The following is a description of a gene set: Genes up-regulated in liver from mice with liver specific knockout of POR. studied in species Mus musculus from publication Weng Y, DiRusso CC, Reilly AA, Black PN, Ding X (PMID 16006652) Mouse Gene Set: WENG_POR_TARGETS_LIVER_UP NADPH-cytochrome P450 reductase (CPR) is an essential component for the function of many enzymes, including microsomal cytochrome P450 (P450) monooxygenases and heme oxygenases. In liver-Cpr-null (with liver-specific Cpr deletion) and Cpr-low (with reduced CPR expression in all organs examined) mouse models, a reduced serum cholesterol level and an induction of hepatic P450s were observed, whereas hepatomegaly and fatty liver were only observed in the liver-Cpr-null model. Our goal was to identify hepatic gene expression changes related to these phenotypes. Cpr-lox mice (with a floxed Cpr gene and normal CPR expression) were used as the control. Through microarray analysis, we identified many genes that were differentially expressed among the three groups of mice. We also recognized the 12 gene ontology terms that contained the most significantly changed gene expression in at least one of the two mouse models. We further uncovered potential mechanisms, such as an increased activation of constitutive androstane receptor and a decreased activation of peroxisomal proliferator-activated receptor-alpha by precursors of cholesterol biosynthesis, that underlie common changes (e.g. induction of multiple P450s and suppression of genes for fatty acid metabolism) in response to CPR loss in the two mouse models. Additionally, we observed model-specific gene expression changes, such as the induction of a fatty-acid translocase (Cd36 antigen) and the suppression of carnitine O-palmitoyltransferase 1 (Cpt1a) and acyl-CoA synthetase long chain family member 1 (Acsl1), that are potentially responsible for the severe hepatic lipidosis and an altered fatty acid profile observed in liver-Cpr-null mice., and this is the list of marker genes: Ces2c, Tmem176a, Dhcr24, Tmem97, Msmo1, Cyp2a4, Prnp, Ces2a, Pgd, Slco1a4, Cyp2c55, Cyp7a1, Gadd45b, Anxa5, Gstm2 (NCBI Gene Id 14863), Sqle, Cyb5b, Ethe1, Cyp51, Asns, Ugdh, Gstm1, Gstm3, Lpl, Idi1, Hmox1, Lgals1, Cldn3, Lgalsl, 4931406C07Rik, Gstt3, Csad, Fdps, Gsta2, Gstm6, Antxr2, Scd1, Entpd5, Cyp2b10, Actg1, Cd36, Cyp26a1, Ahr, Aldh1a7, Aqp8, Ugt2b34, Hmgcs1